Given this list of marker genes MEIS3, METTL9, CDIPT, AREG, STK4, MAT2B (NCBI Gene Id 27430), CAPG, MAN1A2, RHBDL1, STAMBPL1, RIPOR2, TNFSF10, NCK1, LTA, PPP1R13B, RIPK3, PSTK, LHFPL2, STIM1, KCNAB2, NLE1, LY75, ARMC3 (NCBI Gene Id 219681), SMCO4, GALNT10, PRRC2B, TNFAIP8L2, WASHC3, FAM3C, BCL9L, TDRKH, GGACT, KCNA3, FAM117A (NCBI Gene Id 81558), RNF19A, SMOX, PGK1, KCNMB4, GSTT2, CCS, CPM, GPN3, UTP4, GBP7, CISH, ARV1, MRPL58, ZAP70, EMG1, VIPR1, PARD6G, ANKIB1, SLC20A1 (solute carrier family 20 member 1), BCDIN3D, SDF4, ARHGEF18, HCST, LRRC75B, ACY1, TMEM65, ARHGAP29, PLXNA2, ACSL3, ALDH6A1, ZBTB25, KCNK10, CEP97, DSEL, NLK, CERS4, KLF7, IGHM, PTRH1, LGR4, APBB3, RAC2, NDRG3, RASA2, OSBPL9, KCNN4, SELL, BACH2, NAA30, RGS10, RASAL3, ELP3, NARS2, EFCAB2, RPL37A, HECA, NOP10, PPM1J, SFMBT2, ELOVL6, TANC1, SIGIRR, CISD3, CTPS2, GALC, ZNF639, IMPDH1, FBXL12, METTL8, FAM118A, SARAF, FOCAD, PPIC, TRAF3IP3, SLC16A1, S100A13, GRK6, ZDHHC15, DGKE, RABIF, MACROD1, RFTN1, IL18R1, INPP1, XRCC4, POLM, IFT80, RPL13A, GRAMD4, PPARGC1B, ALDOA, EIF3H, RAPGEF6, GOLM1, PATJ, CBR1, OCRL (NCBI Gene Id 4952), GBP2, ZFP82, SLC35B3, IGF2BP2, GALNT2, RPL12, BDH1, SLC17A9, EOMES, LINC00511, KLHL6, STAT4, SUN1, RAB23, GTF2I, TREML2, INSL6, RALGPS2, RPL30, ICAM2, CYTH1, ACTN3, RCBTB2, TEX264, ARID5A, SNX4, C8orf82, IGFLR1, UBXN6, FAM210B, SOD2 (superoxide dismutase 2), MTFR1, KLF3, WDR4, ADPRM, GGT1, CD200, SFXN4, CCM2, HSD11B1, UNKL, ADD3, FRMD8, RPL17, EXOC6B, ACAP1, OXCT1, XKRX, PRMT2, ENTPD5, BOLA2, ARHGAP31, POU6F1, HBP1, GALNT7, RFFL, USP3, HSD17B10, GUCA1B, RPS2, OXR1, MIF, PRKCZ, LDB1, TBC1D10C, SORCS2, NMNAT3, CHCHD10, PIP4P2, here is a description of the gene set: We noticed that ThPOK repression is readily abrogated upon in vitro TCR stimulation of peripheral CD8 T cells. This observation prompted us to investigate a role of ThPOK in the CD8 T cell response to an acute viral infection. We observed that clonal expansion is significantly less in both primary and secondary CD8 T cell responses in the absence of functional ThPOK. To approach this mechanism, we carried out a microarray analysis for comparison of gene expression between ThPOKhd/hd and ThPOKwt/wt P14 memory T cells. Genes up-regulated in memory CD8 T cells: wildtype wt versus ZBTB7B knockout. Human Gene Set: GSE17812_WT_VS_THPOK_KO_MEMORY_CD8_TCELL_UP studied in species Homo sapiens from publication Setoguchi R, Taniuchi I, Bevan MJ (PMID 19734230)